The following is a description of a gene set: electronically inferred by orthology from the curated human pathway Reactome Pathway: PI-3K cascade:FGFR3 This event has been computationally inferred from an event that has been demonstrated in another species.<p>The inference is based on the homology mapping from PANTHER. Briefly, reactions for which all involved PhysicalEntities (in input, output and catalyst) have a mapped orthologue/paralogue (for complexes at least 75% of components must have a mapping) are inferred to the other species. part of: Downstream signaling of activated FGFR3 species: Mus musculus, and this is the list of marker genes: Fgf23, Fgf17, Fgf8, Grb2, Fgf16, Fgf2, Fgf20, Gab1, Fgf1, Frs2, Fgf4, Fgf5